Given this list of marker genes DNAH8, PAK3, ACSM5, BEAN1, CENPP, MAPRE3, HECTD4, BAIAP3, OLFM2, SFPQ, BLTP3A, SV2C, CSF1, PLEKHS1, TCL1A, YME1L1, CIAPIN1, GTF2A1, CARNMT1, COLQ, SLC17A7, PGM2L1, USP34, EFCAB13, SLC51A, ZKSCAN7 (NCBI Gene Id 80241), FSTL1, IL22RA2, HYKK, ENTPD5, PDS5A, WASF2 (WASP family member 2), BABAM2, TSPAN9, PTPN3, GJB4, OAS1, BLOC1S3, NR2C1, CSTPP1, GAMT, NDST1, CASTOR3P, DENND1C, CANX, KLK4, SLC24A2, CCNT1, CTDSP1, MCMBP, VASH2, GK5, GANC (glucosidase alpha, neutral C), ANKRD63, EIF1, ZNF614, TMEM87B, CNNM2, LY6G5C, DHH, NCCRP1, HUS1, PPP3R1, TENM2, DTX4, VAMP1, FAXDC2, SLC4A10, HYDIN, here is a description of the gene set: Human Gene Set: MIR6875_5P Genes predicted to be targets of miRBase v22 microRNA hsa-miR-6875-5p in miRDB v6.0 with MirTarget v4 prediction scores > 80 (high confidence targets). species: Homo sapiens from publication Chen Y, Wang X (PMID 31504780)